The following is a description of a gene set: The physiological process in which dietary excess is sensed by the central nervous system, resulting in a reduction in food intake and increased energy expenditure. species: Mus musculus Mouse Gene Set: GOBP_RESPONSE_TO_DIETARY_EXCESS, and this is the list of marker genes: Pnpla3, Cntnap2, Col6a1, Cckar (NCBI Gene Id 12425), Gpr39, Sorl1, Trpv1, Nmur2, Bmp8b, Pcsk1n, Gfral, Pparg (NCBI Gene Id 19016), Enpp1, Sct, Acvr1c, Sgip1, Trpv4, Sctr, Gdf3, Tbl1xr1, Mc4r, Prlh, Rasal2, Vgf, Appl2, Rmi1, Stk39, Lipa, Adrb3, Mapk14, Lep, Gdf15, Slc25a25, Clic5, C1qtnf4, Apoe, Cntn2, Ucp1, Adrb1, Oma1, Wnk4, Guca2b (NCBI Gene Id 50499), Adrb2, Cfh, Ppargc1a